Given this list of marker genes Ang2, Sulf1 (sulfatase 1), Sost, Nell2, Chodl, Zfp207, Adamts15, Reg4, Nrp1, Rspo1, Adamts5, Vit, Slit2, Defb15 (defensin beta 15), Bmp7, Cfhr4, Ccl8, Lyve1, Ang, Mcpt9, Rspo3, Cd44, Bcan, Abi3bp, Lrpap1 (low density lipoprotein receptor-related protein associated protein 1), Usp17la, Itgam, Vegfb, Hapln3, Tnfaip6, Reg3g, Hyal2, Bsph1, Pcolce, Col11a1, Furin, App, Mstn, Fgfr4, Fn1, Ccl7 (C-C motif chemokine ligand 7), Hk1, Mdk, Serpina10, Cma2, Extl2, Reg1, Fgf10, Fgfr1, Fgf9, Thbs3, Colq, Ptprs, Dcn, F11, Spock3, Usp17ld, Chrd, Ccn3, Col28a1 (NCBI Gene Id 635185), Clec3b, Ccn1, Rpl29, Vcan, Tmem184a, Ptprc, Tlr2, Adamtsl5, Itih4, Ang6, Sema5a, Lpl, Rspo2, Col23a1, Sulf2, Pla2g5, Ndnf, Impg2, Hdgf, Lysmd3, Cfhr2, Ang4, Ptprf, Fgf14, Liph, Acan, Adamts1, Ptn, Ambp, Ccn5, Fbn1, Fgf7, Pdcd5, Habp4, Vtn, Fgf2, Impg1, Ccl5, Tpsb2, Pglyrp3, Layn, Alk, Mmp7, Angptl3, Ncam1, Bmp4, Nod2, Cxcl10, Tnfrsf11b, Eng, Bgn (NCBI Gene Id 12111), Ccl2 (NCBI Gene Id 20296), Ptch1, Cemip (NCBI Gene Id 83495), Prelp, Bsph2, Prss34 (NCBI Gene Id 328780), Gfra2, Hapln1, Smoc2 (SPARC related modular calcium binding 2), Smoc1, Rspo4, Gns, Ang5, Trem2, Fstl1, Sfrp1, Nrtn, Col5a1, Prss57, Hrg, Nrp2, Apoh, Lgr4, Vegfa, Fgfrl1, Pcolce2, H1f1, Usp17le, Ccn2, Adgrg1, Cxcl13, Fbln7, Rtn4r, F2, Adamts8, C1qbp, Ccn4, Apoa5, Fgf1, Grem2, Usp17lb, Agrn (NCBI Gene Id 381587), Ctsg, Postn, Reg2, Tgfbr3, Aoc1l3, Ppia, Col13a1, Ccdc80, Hsd17b12, Selp, Slit1, Mpo, Hmmr, Fgf12, Pcsk6, Fgfr2, Adgre5, Lxn, Pla2g2d, Hapln4, Aoc1l1, Pdcd5-ps, Zg16, Hbegf, Pglyrp1, Gpnmb, Col25a1, Fgfbp3, Prnp, Apoe, Itih2, 2300002M23Rik, Ighm, Ncan, Twsg1, Serpinc1, Rpl22, Nod1, Crispld2, Thbs1, Defb34, Aplp1, Trem3, Tgfbr3l, Rtn4rl1, Tnxb, Usp17lc, Jchain, Aoc1l2, Lipi, Dpysl3, Saa1, Itih1, Hapln2, Ecm2, Comp, Cfh, Slit3, Thbs4, Mamdc2, Aplp2, Egflam, Hmgb1, Serpine2, Lipc, Elane, Pf4, Nav2, Reg3b, Stab2, Efemp2, Igfals, Thbs2, Stab1, Dmbt1, Reg3d, Pglyrp4, Aoc1, Cxcl11, Lipg, Eva1c, Col5a3, Ccn6 (cellular communication network factor 6), Nell1, Spock2, Ltbp2, Serpind1, Lamc2, Reg3a, Tgfbr2, Apob, Pglyrp2, Ltf, Shh, here is a description of the gene set: species: Mus musculus Mouse Gene Set: GOMF_GLYCOSAMINOGLYCAN_BINDING Binding to a glycan (polysaccharide) containing a substantial proportion of aminomonosaccharide residues.